Given this list of marker genes VDR, TRPV4, TG, GPX4, MATN3, MIR140, CYP27B1, KCNH1, B3GALT6, HESX1, TPO, FGFR2, PISD, COL9A3, SOX9, DDRGK1, LONP1, ESR1, LHX3, CYP2R1, LHX4, PROP1, TSHR, RNU4ATAC, POU1F1, TSHB, DUOXA2, DUOX2, KIF22, CLCN5, IYD (iodotyrosine deiodinase), SLC5A5, IARS2, SLC34A3, PAM16, TONSL, KIF7, PTH1R, INPPL1, COL2A1, CYP19A1 (NCBI Gene Id 1588), COMP, here is a description of the gene set: studied in species Homo sapiens Human Gene Set: HP_DELAYED_EPIPHYSEAL_OSSIFICATION Delayed epiphyseal ossification